The following is a description of a gene set: Any process that modulates the rate, frequency or extent of pancreatic juice secretion, the regulated release of pancreatic juice by the exocrine pancreas into the upper part of the intestine. Mouse Gene Set: GOBP_REGULATION_OF_PANCREATIC_JUICE_SECRETION species: Mus musculus, and this is the list of marker genes: Wnk4, Stk39 (NCBI Gene Id 99416), Npr3, Wnk3, Nr1h2 (nuclear receptor subfamily 1, group H, member 2), Wnk1, Nr1h3, Sct